Given this list of marker genes CD34, TNFRSF1B, NECAB1, TXNIP, MRGPRF, F2R, TGFBR2, TF, MMP3, CCDC82, ABCA6, VWF, TEK, SELENOP, PECAM1, ALDH1L1, SFRP1, CIDEC, RPL34, FABP4, IGF1, TNXB, ERG, FOXN3, SYNE3, POU2F2, GDPD2, EMCN, ELN, RCSD1, CAV1, ADAM11, ALDH1A1, ADIPOQ, OMD, DPT (dermatopontin), PIK3CD, SPARCL1, MARCHF7, NGFR, TUBB6, ADCY2, RBP4, MFAP4, RPL31, PDK4, here is a description of the gene set: studied in species Homo sapiens Genes down-regulated in the invasive ductal carcinoma (IDC) compared to the invasive lobular carcinoma (ILC), the two major pathological types of breast cancer. Invasive ductal carcinomas (IDCs) and invasive lobular carcinomas (ILCs) are the two major pathological types of breast cancer. Epidemiological and histoclinical data suggest biological differences, but little is known about the molecular alterations involved in ILCs. We undertook a comparative large-scale study by both array-compared genomic hybridization and cDNA microarray of a set of 50 breast tumors (21 classic ILCs and 29 IDCs) selected on homogeneous histoclinical criteria. Results were validated on independent tumor sets, as well as by quantitative RT-PCR. ILCs and IDCs presented differences at both the genomic and expression levels with ILCs being less rearranged and heterogeneous than IDCs. Supervised analysis defined a 75-BACs signature discriminating accurately ILCs from IDCs. Expression profiles identified two subgroups of ILCs: typical ILCs ( approximately 50%), which were homogeneous and displayed a normal-like molecular pattern, and atypical ILCs, more heterogeneous with features intermediate between ILCs and IDCs. Supervised analysis identified a 75-gene expression signature that discriminated ILCs from IDCs, with many genes involved in cell adhesion, motility, apoptosis, protein folding, extracellular matrix and protein phosphorylation. Although ILCs and IDCs share common alterations, our data show that ILCs and IDCs could be distinguished on the basis of their genomic and expression profiles suggesting that they evolve along distinct genetic pathways. from publication Bertucci F, Orsetti B, Nègre V, Finetti P, Rougé C, Ahomadegbe JC, Bibeau F, Mathieu MC, Treilleux I, Jacquemier J, Ursule L, Martinec A, Wang Q, Bénard J, Puisieux A, Birnbaum D, Theillet C (PMID 18490921) Human Gene Set: BERTUCCI_INVASIVE_CARCINOMA_DUCTAL_VS_LOBULAR_DN